The following is a description of a gene set: Human Gene Set: GSE3982_NEUTROPHIL_VS_EFF_MEMORY_CD4_TCELL_DN Genes down-regulated in comparison of neutrophils versus effector memory CD4 T cells. from publication Jeffrey KL, Brummer T, Rolph MS, Liu SM, Callejas NA, Grumont RJ, Gillieron C, Mackay F, Grey S, Camps M, Rommel C, Gerondakis SD, Mackay CR (PMID 16474395) studied in species Homo sapiens In the present study we used Affymetrix oligonucleotide microarrays to produce gene transcription profiles for the major leukocyte types in humans. This comprehensive dataset enabled us to not only establish which genes were expressed in each leukocyte type, but also which genes were expressed in each subset after activation. The used of a comprehensive dataset of gene profiles from all the major human leukocyte subsets enabled a novel and powerful means for identification of genes associated with single leukocyte subsets, or different immune paradigms., and this is the list of marker genes: TDRKH, SSB, AIMP2, PTER, ILVBL, GYPC, SSR4, EED, ZZZ3, WEE1, TTC4, GUCY1B2, ZNF266, HEATR6, SNRPF, CSRP1, RPL35A, ABCC10, LAX1, CETP, CDH10, RITA1, VPS13D, PTPRO, AKR7A2, ECI1, HLA-DPA1, ACOT11, CCNA2 (NCBI Gene Id 890), MTRF1, SERBP1, CPT1A, SLC25A6, NSD2, C1S, ZC3H14, GSTM2, CACNG3, HAUS5, CYC1 (NCBI Gene Id 1537), UTP18, CDKL3, ZNF665, S1PR1, AKIP1, FAM162A, TTC13, SUPT3H, SIDT2, YARS1 (tyrosyl-tRNA synthetase 1), NDUFB8, RAN, RIOX2, PTPRCAP (NCBI Gene Id 5790), EEF1A1, STOML1, MRPL40, ESD, TSNAXIP1, H2AC17, ILKAP, MAT2A, DIMT1, ANAPC5, RAB29, TASOR, DYNC1I2, IL2RA, ADCK2, ABL1, RAB3GAP2, TXN2, FTO (NCBI Gene Id 79068), CD3E, MAZ, RPL13A, CD81, DSCC1, RFX7, STUB1, RPS3A, VGLL4 (vestigial like family member 4), CAPRIN2, ABHD17A, SERPINA10, OSBPL3, MRPL12, NAA38 (NCBI Gene Id 84316), DNMT3A (DNA methyltransferase 3 alpha), CRYZ, CYP2E1, UPF3A, ARHGAP33, OCLN, PPARD, MYC, RABGGTB, CLEC2D, CCNT2, FAM204A, SLAMF1 (NCBI Gene Id 6504), NUCKS1, CYFIP2, TMX2 (thioredoxin related transmembrane protein 2), CASP8AP2, KRTAP2-4, CRISP1, HEATR3, CDYL, SCN2B, HARS1, STARD7, NELFCD, ACKR2, MALT1, HCRTR2, CHMP6, DPM3, KLHL20, ZNF395, MNAT1, ARSF, GPN3, EIF2B3, AKAP1, YTHDC2, VHL, EEF1D, XPO1, PRKCH, RPS16, MAPRE2, ZDHHC24, AKAP11, KAT2A, CAMK4, ACYP1, POLR2G, MRM2, LINC00339, TAF11, BANF1 (barrier to autointegration nuclear assembly factor 1), RPL10L (ribosomal protein L10 like), FANCE, SAMM50, PAAF1, SH3GL2, ARID5B, MDC1, SHPK, IL15, RPN2, IFNG, POLR3C, KRT37, ZNF74, SCYL3, TMEM120B, DNAJC16, CD164, KIF2A, NDUFAB1, PCNT, JCHAIN, FADS2, CCNC, C2orf42, PAICS, NENF, CYP39A1, TCEA1, OSGIN1, STXBP1, PIBF1, SSBP3, ETFA, CAPN15, ATMIN, NUP155, TAF1, STAG3, MORC2, PCID2, HOPX, PPOX, PTPN4, TNPO3, POLR1HASP, PID1, PTGES3, PUS7, DCUN1D4, OGFOD1, MTSS1 (MTSS I-BAR domain containing 1), PASK, PNP, STOML2, AMBRA1, SCP2 (sterol carrier protein 2)